The following is a description of a gene set: from publication Chen Y, Wang X (PMID 31504780) studied in species Mus musculus Mouse Gene Set: MIR_7075_3P Genes predicted to be targets of miRBase v22 microRNA mmu_miR_7075_3p in miRDB v6.0 with MirTarget v4 prediction scores > 80 (high confidence targets)., and this is the list of marker genes: Bpnt2, Ppm1e, Zfhx4 (NCBI Gene Id 80892), Usp14, Ptprz1, Dmbx1, Dlg1 (NCBI Gene Id 320792), Dzip3, G2e3, Atl1, Pyurf, Spag9, Trpc1, Tnpo1, Mapk8, Cmpk1, Crebl2, Ube2n, Set, Cacnb2, Rgn, Mmd, Pcf11, Btla, Psma2, Zfp287, Nell2, Ccng2, Psg25 (NCBI Gene Id 114868), Cd38, Abi1, Lrp12, Tnpo3, Tent2, Foxa1, Rpgrip1l, AI593442, Lsm5, Pclo, Gpn1, Oga, Abraxas2, Cntf, B3glct, Sdhd, Kpna4 (karyopherin subunit alpha 4), Arhgef11, Pate3, Kctd14, Rb1cc1, Sfpq, Slc18a2, Scn4b, Nufip2, Magt1 (NCBI Gene Id 69751), B3galt1